Given this list of marker genes Mir9-1, Mir99a, Efhd1 (NCBI Gene Id 98363), Mir29c, Mir137, Mir451a, Trpv4, Mir9-2, Xrcc5, Letm1, Abcb1a, Xrcc6, Micu1, Akr1b1, Fbp1, Mir30b, Mir29b-2, Mir204, Mir7b, Slc25a23, Mir434, Mir9-3, Pck1, Mir29b-1, Mir100, here is a description of the gene set: Any process that results in a change in state or activity of a cell or an organism (in terms of movement, secretion, enzyme production, gene expression, etc.) as a result of detection of, or exposure to, an increase in the concentration of salt (particularly but not exclusively sodium and chloride ions) in the environment. Mouse Gene Set: GOBP_HYPEROSMOTIC_SALINITY_RESPONSE studied in species Mus musculus